The following is a description of a gene set: species: Homo sapiens The codon binding activity of a tRNA that positions an activated amino acid, mediating its insertion at the correct point in the sequence of a nascent polypeptide chain during protein synthesis. Human Gene Set: GOMF_TRIPLET_CODON_AMINO_ACID_ADAPTOR_ACTIVITY, and this is the list of marker genes: HYDIN2, LINC02591, ENSG00000227733, LINC03126, LINC01783, MT-TS1, LINC01145